The following is a description of a gene set: species: Mus musculus Mouse Gene Set: REACTOME_HIGHLY_CALCIUM_PERMEABLE_NICOTINIC_ACETYLCHOLINE_RECEPTORS Highly calcium permeable nicotinic acetylcholine receptors, and this is the list of marker genes: Chrna4, Chrna1, Chrna2, Chrnb2 (NCBI Gene Id 11444), Chrnb4, Chrna5, Chrnb3, Chrna6, Chrna3